Given this list of marker genes Lgr4, Pdgfb, Osr1, Cd34, Pdgfrb, Tcf21, Lhx1, Pdgfra, Lamb2, Ret, Agtr2, Aqp1, Nphs2, Egr1, Pax2 (paired box 2), Wt1, Adipoq, here is a description of the gene set: Mouse Gene Set: GOBP_METANEPHRIC_GLOMERULUS_DEVELOPMENT The progression of the metanephric glomerulus over time from its initial formation until its mature state. The metanephric glomerulus is a capillary tuft which forms a close network with the visceral epithelium (podocytes) and the mesangium to form the filtration barrier and is surrounded by Bowman's capsule in nephrons of the mature vertebrate kidney, or metanephros. species: Mus musculus